The following is a description of a gene set: Human Gene Set: GSE43863_NAIVE_VS_TFH_CD4_EFF_TCELL_D6_LCMV_DN Genes down-regulated in CD4 SMARTA T cells: naïve versus effector during acute infection of LCMV. from publication Hale JS, Youngblood B, Latner DR, Mohammed AU, Ye L, Akondy RS, Wu T, Iyer SS, Ahmed R (PMID 23583644) CD4 T follicular helper (Tfh) cells provide the required signals to B cells for germinal center reactions that are necessary for longlived antibody responses. However, it remains unclear whether there are CD4+ memory T cells committed to the Tfh lineage after antigen clearance. Using adoptive transfer of antigen-specific memory CD4+ subpopulations (based on CXCR5 and Ly6c expression)in the LCMV infection model, we found that there are distinct memory CD4+ T cell populations with commitment to the Tfh and Th1 lineages. Our conclusions are based on gene expression profiles, epigenetic studies and phenotypic and functional analysis. The gene expression profiles of virus-specific CD4 T cell subets at effector and memory stages is presented here. species: Homo sapiens, and this is the list of marker genes: C9orf57, CDC14B, SLC25A28, TSSK4, SMAD5-AS1, IL19, ABCB5 (ATP binding cassette subfamily B member 5), FGF14, OPRL1, ARK2C, MT4, IRF8, SH2D1A, TRIM69, SMIM5, CRYBG2, NAGS, FGD2, LALBA, IL18BP, MSR1, PRR14, WIPI2, NPBWR2, ZNF440, LGI3, VPS11, STK31, FAM151A, C19orf25, BATF2 (NCBI Gene Id 116071), CHRNA6, CASP8, MAB21L3, USP30-AS1, UFSP1, CFAP184, HELZ2, PRKCA, EPHA1, GCM1, INPP1, PPP1R14D, TIMP4 (TIMP metallopeptidase inhibitor 4), SHFL, POLR2H, FAM9C, GCH1, MT1G, RGS8, ZFP69B, SLITRK3, LRRC4B, LMO7, ANK3, C14orf28, MZF1-AS1, DCSTAMP, ANGEL1 (NCBI Gene Id 23357), ST8SIA5, SHISAL2A, PARP14, CHIC1, LINC00683, TNF, PRSS36, DRAXIN, MKS1, TNFAIP2, C2CD4B, LITAF, BEX1, CASP10, GNA15, AKR1C4, ADD2, CA5B, CCL18, TENM1, CPB1, RNASE2, SMIM24, CYP11A1, HLA-G, ARID1B, TAF4B, WFDC6, TRAFD1, NLRC5, SERPINA6, FGF11, C2orf92, KIRREL3, CHRM3, ADAM18, TNFRSF1A, TEX46, FLRT1, ACTA2-AS1, DEFB119, OTUD7A, DLGAP1-AS3, ZFP2, PRR36, RHOH, SRY, CST7, CLVS2, VRK3, LPAR5, TREM2, TNNI3, DPPA5P4, GADD45B, NHLH2, LINC00839, FBXO7, SIGLEC11, SYCP2, IMMP2L, RDH5, TRPC2, C10orf71, SYN3, ANKRD13C-DT, LHFPL1, PCDH20, STUB1-DT, IGKC, GALK1, CCDC17, P3H2, HLA-DPB2, NOD2, PRRT1, LINC01354, NUPR1, LRATD1, DLGAP2, MDGA2, LDB1, DIAPH1-AS1 (NCBI Gene Id 100505658), BCAR4, PLPP2, ANO7, STAT2, GBP1, SLC9B1, FOSB, TECTB, MT1H, FILNC1, KRTAP2-4, ZP1, CFHR4, SLC12A8, STPG3, BMS1P1, AMELY, TRIM29, CPA2 (carboxypeptidase A2), ATP1A2, CARINH, CCL5, C1QB, LINC02175, ADCY5, BVES-AS1, LINC00529, KCNJ14, FOXI1, SV2B, PCSK5, EHMT1, BIK, H6PD, HDHD5-AS1, OPTN, MBD3L2, SPIRE2, METTL21C, OR7E14P, FAM20A, SMIM21, TSGA13, NOP9, ARMC12, ANKS1B, FAM216B, C10orf67, RNF213, TRIM72, FCGR2C